The following is a description of a gene set: species: Homo sapiens Neurotransmitter receptor activity occurring in the postsynaptic membrane that is involved in regulating postsynaptic membrane potential, either directly (ionotropic receptors) or indirectly (e.g. via GPCR activation of an ion channel). Human Gene Set: GOMF_NEUROTRANSMITTER_RECEPTOR_ACTIVITY_INVOLVED_IN_REGULATION_OF_POSTSYNAPTIC_MEMBRANE_POTENTIAL, and this is the list of marker genes: CHRNA6, GRIK1, GRIN2B, CHRFAM7A, GRIK5, KCTD16, CHRNA5, CHRNG, GABRA4, GRIA2, GRIA1, CHRND, GABBR1, GRIN2C, GLRA2, GRID1, GRIK2, CHRNA1, GRIN3B (glutamate ionotropic receptor NMDA type subunit 3B), HTR3E, GABRA3, CHRNB3, CHRNA9, GLRB, GABRG3, GABRR2, GRID2, HTR3A, CHRNA4, HTR3C, GLRA1, CHRNA3, GRIK3, GABRA5, GABRD, CHRNA10, GABRB3, HTR3B, GRIN3A, GABRA1, CHRNB1, GABRG2, GRIN2A, GABRA6, GRIA4, HTR3D, CHRNB4, GABRB2 (NCBI Gene Id 2561), CHRNB2, GABRA2, GABRB1 (NCBI Gene Id 2560), CHRNE, GRIK4, ADRB1, CHRNA2, GRIA3, GRIN2D, CHRNA7 (NCBI Gene Id 1139)